Given this list of marker genes SOX8, HES5, GCM1, OLIG2, PAX6, NFIA, SOX2, NFE2L1, TAL1, NKX2-2, CTNNB1, SOX9, ASCL1, NFIB, here is a description of the gene set: The process in which the developmental fate of a cell becomes restricted such that it will develop into a glial cell. studied in species Homo sapiens Human Gene Set: GOBP_GLIAL_CELL_FATE_COMMITMENT